The following is a description of a gene set: studied in species Homo sapiens Any process that activates or increases the frequency, rate or extent of cold-induced thermogenesis. Human Gene Set: GOBP_POSITIVE_REGULATION_OF_COLD_INDUCED_THERMOGENESIS, and this is the list of marker genes: MFN2, DYNC1H1, CCR2, DBH, DIO2, TRPV2, CAV1, ACADL, CNOT3, STAT6, CEBPB, ACHE, FABP5, DECR1, LEP, FH (fumarate hydratase), EBF2 (NCBI Gene Id 90868), GADD45G (growth arrest and DNA damage inducible gamma), ADCYAP1, GNAS, OGT, CXCR4, IL4 (interleukin 4), SCD, EPAS1, PER2, G0S2, ADRB3, VEGFA, LETMD1 (NCBI Gene Id 25875), PEMT, ZBTB7B, ELOVL6, OXT, PHOX2B, ESRRG, KSR2, GJA1, LEPR, UCP1, ADIPOR2, JAK2, FABP4, PRLR, HCRT, OXTR, PDGFC, PPARGC1A, MFAP2, SMARCA4, UCP2, CMKLR1, OMA1, SYK, LCN2, KDM1A, ELOVL3, ZNF516, PRDM16, IRF4, TRPM8, ADRB2, SLN, PRKAB1, YBX2, ALMS1, GPR3, TSHR, ADRB1, IL18, FFAR4, GHRL, HADH, ALPL, ACSL1, APPL2, IGF1R, IL4R, GRB10, THRA, CD36, PPARGC1B, GATM, SFXN5, LPIN1, IL13, SIRT6, HSF1, KDM3A, FGF21, KDM6B, PLAC8, ADIPOQ, PTH2R, PRKAB2, APC, BSCL2, CPT2, HDAC3, ADIPOR1, EHMT1